The following is a description of a gene set: A structural abnormality of the small intestine. species: Homo sapiens Abnormal small intestine morphology Human Gene Set: HP_ABNORMAL_SMALL_INTESTINE_MORPHOLOGY, and this is the list of marker genes: IL2RA, PLG, IGKC, FOXH1 (NCBI Gene Id 8928), WNT2B, ALG6, TTC8, ADAM17, FANCI, CENPF, IPO8, MST1, PALB2, TBK1, NLRC4, RAD51C, PPP1R12A, BBS10, FRAS1, IL12A, CEP57, HLA-DQB1, CFAP418, NPHP1, CIITA, BUB3 (NCBI Gene Id 9184), BBS1, TGIF1, FANCE, WBP11, MLXIPL, PIGN, KAT6B, BRCA1, STX3, CLMP, XYLT2 (NCBI Gene Id 64132), FANCL, SOCS1, CPLX1, XRCC2, FANCD2, RERE, CD55, FANCA, ARL6, UNC45A, BRIP1 (NCBI Gene Id 83991), FLNA, SPIB, ZIC3, IGHG2, MYCN, TOM1, ZNF699, SIX3, FANCB, MPI, GPR35, MMEL1, CDC45, ALG1, RFWD3, ARPC5, SHH, GLI2, GAS1, CEP290, RTTN (NCBI Gene Id 284278), SKIC3, MIR17HG, FBLN5, GMPPB, BBS4, FGF8, CTBP1, STAT5B, TTC7A, ELN, BBS2, DGAT1, FGFR1, PTEN, BBS12, ALG8, FANCM, MCM6, FANCG, RBM8A (RNA binding motif protein 8A), BRCA2, SYK, FLI1, SKIC2, CDKN1A, ALDH18A1, FBN2, LZTFL1, MAD2L2, SMAD2, SRCAP, ODC1, SUFU, RBM10, NODAL, RELA, MKS1, CDKN2C, CARD8, CXCR4, PERCC1 (proline and glutamate rich with coiled coil 1), ERCC4, EPCAM (epithelial cell adhesion molecule), RAD21, SMAD4, MYH11, PLA2G4A, DIS3L2, RFX6, COG8, STAG2, FOXF1, FOXP3, AP1S1, SLC9A3, SDCCAG8, IFT172 (intraflagellar transport 172), BICRA, MYO5B, TNPO3, DOCK11, CCBE1, AIRE, LTBP1, SLX4, PI4KA, ALG9, WAC, UBE2T, RAD51, WNT7B, PLVAP, ZIC2, PKHD1, KDM3B, CDKN1B, TNFSF15, STAT1, BBS7, RARB (retinoic acid receptor beta), EFEMP2, SLC25A12, SPINK5, FGFRL1, FANCC, CHST14, CRIPTO, LCT, EP300, DISP1, SCLT1, IFT27, BUB1B, MKKS, WNT4, MEN1 (NCBI Gene Id 4221), SEMA4D, LETM1, BBIP1, STAT3, CAMK2A (NCBI Gene Id 815), CFAP45, SAR1B, ARID1B, HLA-DQA1, CEP19, ACTG2, ADAMTS3, SATB2, IRF5, IFT74, DYRK1A, BMPR1A, BBS9, XIAP, POU2AF1, NSD2, IVNS1ABP, DLL1, SCAPER (S-phase cyclin A associated protein in the ER), TNFAIP3, ALG3, FANCF, PMM2, CHD7, BUB1, STRA6, BBS5, TBC1D7 (TBC1 domain family member 7), BLNK (B cell linker), TRIP13, PCSK1, MED12 (mediator complex subunit 12), TCF4, PTCH1, DEF6, PORCN, PET117, CDKN2B, DSE, TRIM32, DZIP1L, PIK3C2A, SALL1, IL12RB1, CDON, WDPCP, LRBA, GPC3, GPC4, FOCAD, GTF2H5